The following is a description of a gene set: studied in species Homo sapiens Human Gene Set: GOMF_CARBOXYLESTERASE_ACTIVITY Catalysis of the reaction: a carboxylic ester + H2O = a carboxylate + an alcohol + H+., and this is the list of marker genes: TNFAIP6, CES3, ALDH2, CES1, CES2, CES5A